Given this list of marker genes CD40LG, BST1, CDHR1, TNFSF13B, DNAJC10, PARP14, CHD5, SAXO4, CYP27A1, MORF4L1, TDRD7, CLP1, SLC22A12, CD300LF, SOCS2, HDC, MPEG1, LY6E, INTU, CALHM6, SPATA6, PLAC8, WAS, BBS9, ZFP3, CFD, PDYN, TG, GATM, SLAMF8, TRO, GNS, MYLK, VNN2, DPF3, IFITM3, RCBTB2, FGL2, RAB33A (RAB33A, member RAS oncogene family), NFIA, COCH, APBA2, ARHGAP15, LDAH, ANXA13, MOGAT2, FBN2, DENND2A, OPN4, TECTA, ENTREP3, ITGA4, NCOA7, TSHZ2, TMCO4, GNG10 (NCBI Gene Id 2790), JCHAIN, ZNFX1, ZNF469, AIDA, TST, AKR1A1, INSL5, DOCK2, GREB1L, ZNF385B, PRDM16, MYOCD, CBY3, ETNK1, CP, PRR15, PIK3IP1, UBXN10, BID, UBA7, HFE, BCAT2, DCLRE1C, LIX1, CYP4A22, ITPR1, LGALS9B, GBP4, PTX4 (NCBI Gene Id 64727), CALY, C5orf15, PKD2, ELAVL2, TIFA, LINC00301, GSN, GAB3, LYPLAL1, RNF213, MYH7B, ACKR2, NFATC1, GTF2A1 (NCBI Gene Id 50857), GPM6B, IRF1, S1PR4, NAALAD2, TINAGL1, CYP2E1, VWF, PNMT, CASP12, IPCEF1, ITGB7, TDO2, LMNTD1, ABHD16A, TMEM140 (transmembrane protein 140), ABL1, MS4A8 (NCBI Gene Id 83661), PMCH, C12orf42, GALNT15, LHX5, IFIT2, IL1RL1, RP2, PTPRE, STING1, WDFY4, ANKRD26, IFIT3, FGD2, ZGRF1, SYK, CEP152, IL2RG, KCTD7, CDH17, GPRIN1, TAOK3, IRF8, PSMB10, RAB9B, PLEKHG4, NRG4, TREML4, FCGR3A, C2, CUBN, POLN (NCBI Gene Id 353497), RNASE6, LIN7A, NUPR1, PAM, GBP2, TTR, DYNLT2, CERS2, P2RY14 (NCBI Gene Id 9934), SPIRE2, RAB3A, MMRN1, GBP6, UBE2L6, ODAM, APOL6, CNIH2, SPMAP1, F10, CCR2, PRKD3, DRP2, KANK2, VWA5A, CERS5, SLC35B4, MGST1, GNB4, SNHG10, DPP10, ZWINT, TREX1, BST2, ICA1, SHISA5, FLT4, PLEKHB2, XDH, INSRR, GDF11, HLA-A, SLC39A3, AGMAT, GBP7, HSD11B1, IL21, CALR3, ORC1, CD300C, OAT, SERPINA10, RESF1, here is a description of the gene set: Human Gene Set: GSE19888_ADENOSINE_A3R_INH_VS_ACT_IN_MAST_CELL_DN We demonstrate that the G protein Gi3 is the cellular target of the adenosine A3 receptor (A3R). By using a cell permeable peptide comprising the C-terminal end of Gαi3 fused to an importation sequence (ALL1) as a selective inhibitor of Gi3 signaling, we show that by coupling to Gi3, the A3R stimulates multiple signaling pathways in human mast cells, leading to upregulation of cytokines, chemokines and growth factors.Following contact with activated T cell membranes, endogenous adenosine binds to and activates the A3R, resulting in Gi3-mediated signaling. Specifically, the majority of ERK1/2 signaling initiated by contact with activated T cell membranes, is mediated by Gi3, giving rise to ALL1-inhibitable cellular responses. These results unveil the physiological GPCR that couples to Gi3 and establish the important role played by this G-protein in inflammatory conditions that involve adenosine-activated mast cells. We used microarrays to detail the effect of ALL1 on gene expression of HMC-1 cells activated directly by the A3 receptor, or by contact with activated T cell membranes. Genes down-regulated in HMC-1 (mast leukemia) cells incubated with: the peptide ALL1 versus Cl-IB-MECA. species: Homo sapiens from publication Baram D, Dekel O, Mekori YA, Sagi-Eisenberg R (PMID 20190146)